The following is a description of a gene set: Genes containing one or more binding sites for (BRF1) in their promoter regions (TSS -1000,+100 bp) as identified by GTRD version 20.06 ChIP-seq harmonization. from publication Yevshin I, Sharipov R, Kolmykov S, Kondrakhin Y, Kolpakov F (PMID 30445619) species: Homo sapiens Human Gene Set: BRF1_TARGET_GENES, and this is the list of marker genes: PPP6R3, LASP1, TRIM7-AS2, B4GAT1-DT, AGBL5-AS1, KNL1, SMARCC2, PAMR1, HCG14, POLR3E, LINC01623, LINC01556 (long intergenic non-protein coding RNA 1556), AGBL5, PLXDC1, LRP3, DPP9, MCRIP2, ALOXE3, PPEF1, PRMT5-DT, LINC01962, RNASE4, RNASE11, BCAR3, H4C8, FBXO31, LINC02136, MYNN, VTRNA1-1, HJV, VTRNA1-3, TIA1, PLEKHG2, NDUFS7, FMC1-LUC7L2, NCOA7, HMGN4, H3C9P, VTRNA2-1, WASF4P, RAB11A, CFAP418, ZNF839, ANG, POLG-DT, POLG, FMC1, HSPA6, LINC02453, ILF2, PRMT5, METTL26, ELF1, B4GAT1, VTRNA1-2, MIR4521, C2orf42, MAP1LC3B, SHF, LIMD1-AS1, WBP4, SACM1L, PSMB3, TRIM41, LTA4H